The following is a description of a gene set: species: Mus musculus A G protein-coupled receptor signaling pathway initiated by tachykinin binding to its receptor on the surface of a target cell, and ending with the regulation of a downstream cellular process. Tachykinin is a short peptide with the terminal sequence (Phe-X-Gly-Leu-Met-NH2). Mouse Gene Set: GOBP_TACHYKININ_RECEPTOR_SIGNALING_PATHWAY, and this is the list of marker genes: Tac2, Tacr2, Grk2, Tac1, Tacr1, Tacr3, Grk5, Tac4